Given this list of marker genes CBX7, FOXP4, SHISA6, C3orf18, HS6ST1, SCARA5, NOVA2, COX10, MPIG6B, VAMP2, RIMKLA, SPINDOC, USP22, PA2G4, IFT140, BARHL1, SCN4B, S1PR2, UBE4A, GRN, NFASC, DHRS11, RARA (NCBI Gene Id 5914), TWNK, CDKN1A, RNF130, RIMS3, VAT1, CDR2L, CLCN7, HLA-DRB1, HECTD3, LSAMP, MECP2 (methyl-CpG binding protein 2), CD4, C20orf203, SPTB, MN1, STIM1, CAVIN1, FIS1, PRX, SLC34A2, NGFR, PFN1, CD300LD-AS1, PPT2, LRRC25, NCDN, TAB1, SH3PXD2A, TIMP2, PROX1, TRIM66, MTCL2, WNK3 (WNK lysine deficient protein kinase 3), CSPG4, KDELR1, SCN4A, SRGAP1, PDZD7, PRKACA, NAAA, NDST3 (NCBI Gene Id 9348), SP6, SFT2D3, KRT3, EPB41L1, NOS2, NACC1, LNX2, RPS24, BTBD9, ERAL1, MYLK2, CSNK1A1, FAM124B, RAB1B, COL5A3, BCAS1 (brain enriched myelin associated protein 1), PEAR1, GRM4, PRKAR1B, CDC42BPA, ALDH7A1, UBIAD1, FAM193B, ETV4, RPS23, PADI2, ZBTB4 (zinc finger and BTB domain containing 4), CIB2, IQSEC3, FBLN5, KIF1A, TBC1D16, POLE3, SIAH3, TRIM3, SYNGAP1, PIRT (NCBI Gene Id 649488), TEAD1, NHERF2, GPD1, OLFML2A, KRTAP10-5, ZNRF1, TNF, DENND6B, ARID3B, NFIC, SLC25A45, DAAM2, CTIF, SPATA31C2 (NCBI Gene Id 645961), LOXL3, GRIK3, CDK10, TAL1, SCAMP4, PAX5, TMBIM1, LCN1, KLHL3, here is a description of the gene set: studied in species Homo sapiens Human Gene Set: MIR1343_5P from publication Chen Y, Wang X (PMID 31504780) Genes predicted to be targets of miRBase v22 microRNA hsa-miR-1343-5p in miRDB v6.0 with MirTarget v4 prediction scores > 80 (high confidence targets).